The following is a description of a gene set: Human Gene Set: GOMF_SOMATOSTATIN_RECEPTOR_ACTIVITY Combining with somatostatin to initiate a change in cell activity. Somatostatin is a peptide hormone that regulates the endocrine system by signaling via G protein-coupled somatostatin receptors. Somatostatin has two active forms produced by proteolytic cleavage: a 14 amino acid peptide (SST-14) and a 28 amino acid peptide (SST-28). species: Homo sapiens, and this is the list of marker genes: SSTR3, SSTR1, SSTR5, SSTR2, SSTR4